Given this list of marker genes PRIM1, RPA1 (NCBI Gene Id 6117), RPA2, FEN1, POLD3, PRIM2, PCNA, LIG1, POLD1, POLD2, DNA2, POLD4, POLA2, RPA3, POLA1, here is a description of the gene set: Human Gene Set: REACTOME_PROCESSIVE_SYNTHESIS_ON_THE_LAGGING_STRAND Processive synthesis on the lagging strand species: Homo sapiens